Given this list of marker genes TTLL1, TTLL4, TUBA4B, VASH1, TTLL8, TUBA8, NICN1, TUBA1A, TUBA1B, TUBB3, AGBL3, TUBB2B, TTLL13, TTLL10, TTLL2, TTLL7, SVBP, LRRC49, TTLL9, TUBB4B, TTL (tubulin tyrosine ligase), AGTPBP1, TUBAL3, TUBB6, AGBL1, TUBA3D, TUBB8, TUBA1C, TUBB4A, TTLL6, TTLL12, TUBA3C (tubulin alpha 3c), VASH2, TUBB8B, AGBL2, TUBA4A, TPGS1, TUBA3E, AGBL4, TPGS2, TUBB1, TUBB2A, TTLL3, TTLL11, AGBL5, TTLL5, here is a description of the gene set: Reactome Pathway: Carboxyterminal post-translational modifications of tubulin part of: Post-translational protein modification studied in species Homo sapiens Tubulins fold into compact globular domains with less structured carboxyterminal tails. These tails vary in sequence between tubulin isoforms and are exposed on the surfaces of microtubules. They can undergo a variety of posttranslational modifications, including the attachment and removal of polyglutamate chains and in the case of alpha-tunulins the loss and reattachment of a terminal tyrosine (Tyr) residue. These modifications are associated with changes in the rigidity and stability of microtubules (Song & Brady 2015; Yu et al. 2015).<br>Mutations affecting these modification processes can have severe effects on phenotype (e.g., Ikegami et al. 2007). Nevertheless, the precise molecular mechanisms by which these changes in tubulin structure modulate its functions remain unclear, so these modification processes are simply annotated here as a series of chemical transformations of tubulins.